Given this list of marker genes AP2A1, nef, AP2B1, AP1M1, AP1M2, AP1G1, LCK, ATP6V1H, AP1S1 (NCBI Gene Id 574017), CD4, AP1S3, PACS1, AP1B1, AP2A2 (NCBI Gene Id 25955), HLA-A, AP2S1, B2M (beta-2-microglobulin), AP1S2, CD28, AP2M1 (NCBI Gene Id 1173), ARF1, CD8B, here is a description of the gene set: The maximal virulence of HIV-1 requires Nef, a virally encoded peripheral membrane protein. Nef binds to the adaptor protein (AP) complexes of coated vesicles, inducing an expansion of the endosomal compartment and altering the surface expression of cellular proteins including CD4 and class I major histocompatibility complex.<br> Nef affects the cell surface expression of several cellular proteins. It down-regulates CD4, CD8, CD28, and major histocompatibility complex class I and class II proteins, but upregulates the invariant chain of MHC II (CD74). To modulate cell surface receptor expression, Nef utilizes several strategies, linked to distinct regions within the Nef protein.<br>Since all these receptors are essential for proper functions of the immune system, modulation of their surface expression by Nef has profound effects on anti-HIV immune responses. Down-regulation of MHC I protects HIV-infected cells from host CTL response, whereas down-modulation of CD28 and CD4 probably limits the adhesion of a Nef-expressing T cell to the antigen-presenting cell, thus promoting the movement of HIV-infected cells into circulation and the spread of the virus. Reactome Pathway: Nef-mediates down modulation of cell surface receptors by recruiting them to clathrin adapters part of: The role of Nef in HIV-1 replication and disease pathogenesis species: Homo sapiens